Given this list of marker genes RPL11, BMP4, AKTIP, RAN, MMP9, ADD2, ABL1, DACT1, BAMBI (BMP and activin membrane bound inhibitor), TERT, BDNF, TIAM1, TRIM21, RALB, DTX3L, EPB41, NMD3, USP33 (NCBI Gene Id 23032), USP9X, NVL, IDE, GSK3B, ADD1, RAPGEF2, FLOT1, here is a description of the gene set: Human Gene Set: GOBP_POSITIVE_REGULATION_OF_PROTEIN_BINDING Any process that activates or increases the frequency, rate or extent of protein binding. species: Homo sapiens